The following is a description of a gene set: mouse primary BMDCs were stimulated with tlr ligands and gene expression changes were profiled on Affymetrix arrays Genes up-regulated in comparison of dendritic cells (DC) stimulated with Pam3Csk4 (TLR1/2 agonist) at 6 h versus DC cells stimulated with CpG DNA (TLR9 agonist) at 6 h. Human Gene Set: GSE17721_PAM3CSK4_VS_CPG_6H_BMDC_UP studied in species Homo sapiens from publication Amit I, Garber M, Chevrier N, Leite AP, Donner Y, Eisenhaure T, Guttman M, Grenier JK, Li W, Zuk O, Schubert LA, Birditt B, Shay T, Goren A, Zhang X, Smith Z, Deering R, McDonald RC, Cabili M, Bernstein BE, Rinn JL, Meissner A, Root DE, Hacohen N, Regev A (PMID 19729616), and this is the list of marker genes: LARS1, PSMD2, PRKD2, UNG, TSPAN14, TRMT2A, BIN3, CLPP, MANBA, IL1RL2, TMEM165, MBD3, NUDCD2, PDLIM7, ELOF1, UTP20, EIF2AK4 (NCBI Gene Id 440275), PARVG, SLAIN2, SNRNP48, POLR3D, PRAF2, GTF2H1, ECPAS, RMC1, PPP1R18, B4GALT1, CALR, GATC, GTF3C4, PAGR1, DLG1 (discs large MAGUK scaffold protein 1), FERMT3, TSR2, LPP, AS3MT, JAGN1, CHADL, MMP12, SASH3, GTF2I, DGAT1, MRPL49, ITSN1, BCAS2, GAS2, USP34, DGKQ, TMEM268, NHP2, NOP16, FKBPL, RCC2, CHMP6, CTSA, DHCR24, SMC2, C1R, IL36G, PRKRA, ENTPD4, LTV1, COX19, TMA16, NSMF, NOP2, NFS1, JRK, KDELR1 (NCBI Gene Id 10945), FLCN, PNPLA6, NCAPD2, SDC1, PTGER2, PRSS42P, CALHM5, ERCC3, TTC13, FGR, SMIM11, UNC119, SRSF6, WDR13, FUT4, SIRT7, SAA1, PFKL, MFN2, CDC42SE2 (NCBI Gene Id 56990), PHTF1, TRIM8, NUFIP1, PBXIP1, ETS2, SIRPA (signal regulatory protein alpha), ATP6V0E1, LOXL2, RNF26, NME6, BATF3, IDUA, SNX18, BNIPL, CCT2, KLHDC3, ARMH4, DIAPH1, SENP3, TMLHE, CREBZF, ACADM, PPP1R14B, SNAPIN, SEPHS2, CLCN3, GAS7, CTNNA1, UBA2, HJURP, CDPF1, PTCD2, TOB2, HSPB8, SPIC, FAM118A, MRPL45, SAE1, LPCAT3, SNX1, IFNGR1, SMC6, TCEAL8, AGAP1, PLEC, RPS16, QNG1, PHB2, NCBP1, DPH5, R3HDM1, EIF2S3, GPR85, PSMD5, MARCO, PSMG3, NUP210, KLF7, YY1 (NCBI Gene Id 7528), MSANTD3, SPRED2, NAPG, PDE8A, WDR6, GRAMD4, FANCE, SVIL, RPS6KA1, MLLT10, SAC3D1, STAB1, XPO5, CDC6, SRPK2, GAL3ST1, MRPS26, PGM2, DNLZ, MRPS7, SARS1, SLC25A3, TBCE, COTL1, RPL9 (NCBI Gene Id 6133), LZTR1, ATF2 (activating transcription factor 2), PRPF39, WNT6, ZZZ3, EBP, PABIR1, C7orf25, ZNF318, AMPD2, KLF1, ADSL, TACC2, DHCR7, TMEM184C, SNX17, NDUFA8, PAICS, SLC25A10, LRRC59, NAA15, ATG5, SMIM30, EVI5, CAMK1D, DNAJC21, SKP2